Given this list of marker genes Or56b2l-ps1, Msantd7, Gm16759, Insig1, Ivd, Snx17, Psma7, Trappc14, Gls, Tet2, Hnrnpl, Dpp9, Ppid, Klc2, Nit1, Yaf2, Ogfod2, Pcif1, Bmp7, Dynll1, Gm13830, Cep63, Ddx27, Pgls, Cramp1, 1700037C18Rik, Tpgs2, Mir5615-1, Tecpr1, Gm12830, Gm5914, Men1, Dlst, Hint2, Tstd2, Mkln1os, Gm20324, Slmap, Aff4, Cfap57, Pafah1b1, Slc39a9, Iqce, Hmgb1, Srgap2, Gm15018 (NCBI Gene Id 100040987), Per1, Gm9887, Pigu, Dpm1, Cyb5rl, Gm17232, Chkb, Ociad1, Birc5, Gm17690, Ddx18, Tm9sf4, Jpt1, Bcar3, Gm4219, Dpm2, Nudt19, Pih1d2, Shpk, Tmed3, Styxl1, Polr2b, Rapgef1, 4930579G24Rik, Rbck1 (RanBP-type and C3HC4-type zinc finger containing 1), Exoc6b, Ncbp2as2, Dcp2, Psmd3, Cluap1, Hsp90aa1, Tor1aip1, Mideas, Mtg2, Ap1m1, Tbcd, Fyttd1, C030034I22Rik, Slc25a29, Dnajb14, Vcp, Polr1a, Rnf123, Pomgnt1, Plekhj1, Cspp1, Crtc2, Arih1, Bbs12 (Bardet-Biedl syndrome 12), Hdac7, Tor1a, Mesd, Dennd3, Gm28513 (NCBI Gene Id 329271), Npm1, Ift52, Tbpl1, Cd164, Mir195b, Brap, Snord49b, A430072P03Rik, Coa7, Sf3a2, Jarid2, Ptges2, Brd3, Entpd6, Tmem106b, Thap12, Zfp451, Map1lc3b, Mgat5, Agrp, Hyal3, Gpr12, Foxj3, Dnmt3b, E230015B07Rik, D030040B21Rik, Brix1, Map3k3, Slc2a1, Trim46 (tripartite motif-containing 46), Mia2, Etaa1os, Ift140, Rnu11, Ppie, Cpsf4, Trp53inp2, Mindy1, Gm34583, Pabir1, Mtmr4, Rps10, 0610031O16Rik, Ncbp2, Nup42, Mospd3, Psmc3, Cdc27, Fam98b, Dbr1, Chic2, Cd84, Dhrs11, Adck2, Mtarc2, Srp68, Tmprss11g, Nudcd3, Rplp0, Psmb8, Kank1, Arsa, Zdhhc16, Eif4g2, Tut4, Extl2, Poc1a, Atxn7l3, Zbtb7b, Mir142, Ttc33, mt-Cytb, Rpl7a, Sys1, Dido1, Srsf5, Pias3, Luc7l2, Gm22357, Scn8a, Psmb4, Trim39 (tripartite motif-containing 39), Xpo6, Bora (NCBI Gene Id 77744), Abcb6, Naa20, Zgpat, Psmb9, Ric1, Fmc1, Vamp2, Dhrs1, B230354K17Rik (RIKEN cDNA B230354K17 gene), Mir6935, Add1, Usp40, Gm11695, Naa12, Gm4285, Blcap (bladder cancer associated protein), 8430423G03Rik (RIKEN cDNA 8430423G03 gene), Sri, Hdac4, Bcap29, 1700123M08Rik, Ankrd40, Phtf1os, Zbtb37, Ica1l, Slc39a10, Nhlrc3 (NCBI Gene Id 212114), Uck1, Sbf1, Gm9694, 4930580E04Rik, Fam133b, Mir7075, Gbp3, Gm15564, Itgb1, Rhot2, Tmed7, AW554918 (NCBI Gene Id 225289), Faf1, Cacfd1, Gm14966, Mettl8, Atp6v0b, Cdin1, Timm17a, Rnf146, Cdk6, Chmp3, Cgrrf1, Uqcrc2, Gm12279, Gm26787, Gatad1, Anapc13, Stam, Npepl1, Plgrkt, Abhd4, Alg3, Rgs22, Ndufab1, Tigd5, Cyb5r4, Maml1, Erbin, Slc4a8, Kpna7, 9130401M01Rik, Alg9, Gm20716, Mfap3, Gm15410, Cct6a, Entpd7, Cdkl2, Eif2b4, Mtdh (metadherin), Mef2a (myocyte enhancer factor 2A), Rpn2, Dera, Gm27011, 0610039K10Rik, Cish, Mon1a, Rpl9, Flvcr1, Sgms1, Atpsckmt, Troap, Atp8b2, Catsper2, Pdss1, Sephs2, Zc3h4, Gt(ROSA)26Sor, 1810009A15Rik, Unc50, Zfp689, Sppl3, Abhd14a, Dennd6b, Cox7c, Utp14b, Invs, Lamtor3, Ncstn, Slc9a8, Setd1a, Ubtd2, Trip4, Wfdc3, Btf3, Oser1, 1110002L01Rik, Yrdc, Mir345 (NCBI Gene Id 723946), Rnft1, Zfp652os, Kctd9, Golga5, Nfe2l1, Gm24016, Mrpl48, Msl2, Sephs1 (selenophosphate synthetase 1), 4932435O22Rik, Arf4os, Foxm1, Gm9828, Tbc1d14, Tnip2, Pphln1, Epn1, Crk, Ptk2, Ubr1, Zbtb41, 4930558G05Rik, Vps54 (NCBI Gene Id 245944), Acp2, Lap3, 5430405H02Rik (RIKEN cDNA 5430405H02 gene), Zfp24, Ubl5, Elmod3, Ulk2, Dhx35, Elp5, Dusp10, Parp9, Pura, Tmem131, Suz12, Fbxl12os, Agk, Nudt3, Gm25222 (predicted gene, 25222), Cetn4, Mia3, Prkacb, Prkar1b, Gabpb1, 1810019N24Rik, 2310058D17Rik, Selenoh, Zkscan6, Tmem63b, Gpx4, Oxsm, Glra1, Slc15a4, Spout1, Spart, Uspl1, Supv3l1, Hsph1, Sun1, Usp5, Snord110, Oaf, Gm29642, Snord45c (NCBI Gene Id 100217425), Tlk1, Nrde2, Gtpbp10, Mdh1b, Adam17, Ece2, Rmrp, Pkn2, 4930583K01Rik, Apaf1, Ctc1, Nifk, Mrpl17, Mrm1, Gm13267, Septin11, Nelfa, AI480526, Fibp, Sfswap, Med23, Rbbp6, Trim44, Pcid2, Vhl, Mgme1, Ywhaq, Gm15938, 4930507D05Rik, Ccdc47, Phykpl, 9230114K14Rik, Gtf2e1, Tnrc6b, Rbbp4, Rad18, Kdm2a (lysine (K)-specific demethylase 2A), Cep44, Eif2a, Mir155hg, Acad12, Ube2d-ps, 4930511O05Rik, Rc3h2, Pnpla2, Atf7ip, Tob1, Stk39 (NCBI Gene Id 99416), Mir7036b, Stt3a (STT3, subunit of the oligosaccharyltransferase complex, homolog A (S. cerevisiae)), Ubap2l, Spopl, Ankib1 (ankyrin repeat and IBR domain containing 1), Ahi1, Ucp2, Espl1, Bap1, Wbp2, Tuba1c, Atp5pf, Smarcc1, Arfrp1, Mm2pr, Jtb, Iqcg, Dcun1d1, Ampd2, Ttpal, Gm11527, C130046K22Rik, Eif4g1, Slc26a6 (NCBI Gene Id 171429), Ccdc107, Exosc1, Elf2, Hirip3, Ints7, Pfdn5, Gm22711, Cdca2, Kiz, Hjurp, Mars1, Nlrp6, Ttc4, Oxa1l, Zwilch, Tmem147, Pwwp2a, Zfc3h1, Rfx1, Pex26, Grk5, Acaa1a, Gm7285, Abi2, Tgfbrap1, Rnf168, Gm11466, Eloc, Brd2, Sh3bp5l, Insig2, Rnf115, Dnaja1, Triap1, Mrps7, St13, Parp1, Hyal5, Ngdn (neuroguidin, EIF4E binding protein), 9430038I01Rik, Dctn2, Mgat4b, 5031425E22Rik, Zmpste24, Etfdh, Psme3, Ahsa2, Rpgrip1l (NCBI Gene Id 73313), Evi5, Alyref (Aly/REF export factor), Nvl, Commd3, Gm13483, Stx16, Rab29, Med27, Cdca7l, Rps27a, Pole4, Zfp592, 2310016D23Rik, Gm14448, Rhno1, Rpl35a, Mrpl32, Ruvbl1, Efcab2, Dnaaf9, Pofut1, Tmed2, Macroh2a1, Irf1, Sphk2, Srsf4, Pex5, Mir431, Cnot2, Fbxo21, Tmem131l, Trrap (NCBI Gene Id 640386), E030042O20Rik, Pnrc2, Snhg15, Xrcc5, Phf7, Kat7, Etfa, Dennd6a, Sharpin (SHANK-associated RH domain interacting protein), Mir467f, Ndufs7, Irf3 (interferon regulatory factor 3), Cnot4, Pds5a, Lamtor2, Cnbd2, Runx1, Crls1, Mta2, Galnt3, 1700016D08Rik, Rpl18, 2900093K20Rik, Spcs1, Metap2, Bscl2, Vrk2, Slc35c1, 1700022N22Rik, Plekha4, Usp19, Fto, Xpo4, Tma16, Tex264, Rabggtb, Tfb1m, Rbm39, Snord43, Ybey, Ndufaf8, Atrn, 1700065D16Rik, 9930004E17Rik, Akr1b1, Strn4, Nudcd2, Gm22879 (NCBI Gene Id 115489587), Htr5a, Azin1, Rcor1, Otub1, Zmynd12, Wdr26, Zfp866, Ino80e, Afg3l1, Snora73b (small nucleolar RNA, H/ACA box 73b), Gm7467, Hdac10, Pex13, Proser1, Prelid3b, Stamos, Ylpm1, Gm19265, Phf3, Or8b47, Adar, Ints5, Rpl31, Snora16a, Zfp764l1, Cox20, Hspd1, Ccdc34, Pogz, S100pbp, Mogs, Mrps2, Akr1a1, Sfi1 (Sfi1 homolog, spindle assembly associated (yeast)), L3mbtl2, Cnih4, Zmynd8, E330011M16Rik, Ubb, Tmem134, Slx1b, Zbtb8os, Man1a2, Coasy, mt-Tl1, Clspn, Naa60, Gm15728, Gm14963, Gm8000, Mir7672, Mir7654, Ranbp1, Ranbp2, Gm8357, Tlk2, Mir686, Bzw1, Snrk, Kdm4b, 1110004F10Rik, Cdc37l1, Spata33, Mrpl37, Tcf12, Pdf, Ppp1r14d, Pcbp3, Zfas1, Cdk9, 1700030C12Rik, Trim27, Lrsam1, Mapk14, Nudt16, Mir1893, Or5b106, Elac2 (elaC ribonuclease Z 2), 2300009A05Rik, Cbfa2t2, Rbsn, Yy1, Rps14, Cd274, Frg2f1, Ube2f, Tln1 (talin 1), Mfn1 (mitofusin 1), Rnf157, Mrtfa, Zfp639 (zinc finger protein 639), Rrp8, Snord49a, Cbx4 (NCBI Gene Id 12418), Atxn2l, Wapl, Paxip1, Snora26, Klf7, Arl8a, Ddrgk1, Prepl, Capzb, 1110020A21Rik, Dsn1, 4933440N22Rik (NCBI Gene Id 74471), Sptlc3, Fasn, Gm23201, Pabpc1, Atpaf2, Slc16a5, Tceanc2, Dyrk1a, Rpn1, Kin, Rbm5, P2rx3, Ube2d3, Gm23205, Aar2, Snord35b, Tfdp1, Ralgapb, Arhgap26, Setd1b, Tmem243, Tmem59, Erap1, Ccdc73, Slc35d1, Gm36527, Slc9a1, Svil, A930007I19Rik, A330035P11Rik, Nup54, Gm26224, Cenpk, Iqck, Gfi1, 3110083C13Rik, Abhd16a, Speer4cos, Plcl2, Aebp2, Elp1, Rsl24d1, Mrpl49, Lias (lipoic acid synthetase), 2210408I21Rik, Abl2, Nbeal1, Kat2a, Nckap5l, Ankrd44, Rbm6, Crem, Letm1, Spata31e2, Cluh, Rbpj, Myl4, Nsmaf, Zfp12, Zfp568, Cul4a, Ppig, Rpl12, Rb1cc1, Dmac2l, Egr1, Eci2, Chmp6, Or4c106, Noa1, Ptp4a1, Gm16208, Agpat3, Zfp646, 2810029C07Rik, Ttc39d, Swi5, Cdc73, Pnrc1, Exoc3, Slc20a1, Mroh8, Tcerg1, Dazap2, Ubxn1, Mrps18a, Drc3, Ppp5c, Tasor, Mre11a, Paip1, 2310061I04Rik, Shmt1, Pdp1, Snap23, Tpm3, Creld2, Phb2, Arid1a, Topbp1, Stag2, Pip4p2, Cox6c, 1700055D18Rik, Mir207, Gm5540, Usp21, Tmbim6, Ppp2r3d, Usp46, Sf3a3, Psmd11, Hdgf, Sppl2b, Zwint, Fbf1, Aldh7a1, Ptcd1, Pik3ip1, Asns, Eif1a, Atp13a3, Supt7l, Myo1c, Mrpl12, Amigo3, Tatdn2, Pus10, S1pr1, Trak2, Snord14a, 4930535L15Rik, Trpm8, Dis3l, Ap3s2, Hspb9, Lmnb2, Dram1, Orc6, Pdia3, Bag5, Trim11, Smim14, Map3k10, Hnrnph1, Vps35, Dcun1d4, Nusap1, Mtbp, N4bp2, Mrpl52, Car7, Msantd5l, Fbxo6, Supt4a, Tfb2m, Rhot1, H2aj, Gm16001, Slc35c2, Ddx39b, Ppp1r18, Pfkfb4, Eif4a1, Degs1, Astn1, Wdr77, Pimreg, Cab39l, Blzf1, Rnf14 (ring finger protein 14), Fbxo33, Rsbn1l, Hmmr, Rassf1 (NCBI Gene Id 56289), Gm12667, Eif4e2, Vps4b, Ccnk, Bud31, 5430434I15Rik, Snhg6 (small nucleolar RNA host gene 6), Smim10l1, Ccnj, Mrtfb, Oard1, Znrf3, Mbd2, Nfe2l2, Wipf1, Pramel7, Pgap2, Als2, Gm24067, Hoxc6, Glo1, Slc7a1, Arfgap2, Omg, Mocs3, 1600020E01Rik, Edf1, Zfp810, Uvssa, Dtx3l, Zmynd19, Pip4p1, 1110065P20Rik, 1700003G18Rik, Kmt2e, Stat5b, Tent4a, Rnf103, Rsph3b, Ctns, Cbll1, Snord2, Zfx, Ccne2 (cyclin E2), Tiparp, Stradb, Hsp90ab1, Hspe1, Gm16794, Cdnf, Ints15 (integrator complex subunit 15), Coa8, 5930411N13Rik, Qrich2, Zranb1, Spdye4b, Ankrd42, Exoc2, Adam9, Casd1, C430014B12Rik, Tonsl, Eef1a1, Cdk2ap2, Rpl26, Rps20, Ppwd1, Ppp1r11, Tagln2, Zfp950, Prpf19, Eif4a2, B4galt3, Minpp1, Gnptg, Rgl1, Evi2b, Rpl32, Naa15, Dnlz, Rnasel, Mpzl1, Abitram, Soat2, Pttg1ip, Rpl6, Fkbp4, Ndrg3, 5430400D12Rik, Ldha, Ccna2, Lrch4 (leucine-rich repeats and calponin homology (CH) domain containing 4), Ufl1, Stk25, Tubgcp4, Zfp777, Dusp28, Bola2, Vamp4, Pcbd2, Slc16a1, Gm13778, Dleu2, Ifnar2, Znrf2, BC049715, 2610206C17Rik, Pradc1, 4931406C07Rik, 2810013P06Rik, Terf2, Lrrc24, mt-Nd1, Arl6ip6, Antxr2, Gm4825, 2810405F17Rik, Toe1, Qrich1, Ptp4a2, Cep350, Wdr73, Akirin2, Cfap68, Gm22107, Gm13610, Rab7, Cdca5, Atp5mk, Snx5, Asb1, Ep300 (E1A binding protein p300), Ndufs8, Ilk, Snhg7os, Defb25, Acad11, Tsacc, Gabpb2, Galnt1, Dus2, Slc25a1 (NCBI Gene Id 76777), Gm11802, Tax1bp3, Pmpcb, Gm25878, Gm40190, Dap3 (NCBI Gene Id 80429), Rsrc1, Cibar1, Senp1, Trappc8, Zfp276, Zdhhc24, Zfp523, Gsap, Tmco1, Utp3, Dram2, Commd6, Usp8, Mir3091, Znhit3, Slc25a19, 4933405D12Rik (RIKEN cDNA 4933405D12 gene), C330013E15Rik, Snord68, Camkmt (NCBI Gene Id 73582), Set, Ptpa, Amfr, Pithd1, Dync2h1, Ddx6, Ei24, Fastk (Fas-activated serine/threonine kinase), Bcl7c, Ddx31, Cdkn2c, Bag1, Zfp668, Sp8, Sap30l, Ikbip, Txndc5, Lrrc41, Psmb7, Nt5m, Epc1, Dclre1a, Rubcn, Dvl3 (dishevelled segment polarity protein 3), Snora7a, Xpnpep3, Rock1, Nufip2, Akap9, Nt5c3b, Zfyve1, Smurf1, Gstp1, Trpc4ap, Mvb12b, Cd27, Stk38, Trbj2-6, 2010109A12Rik, 0610009E02Rik (NCBI Gene Id 100125929), 1600023N17Rik, Nfyb, Tex14, Ipo13, 2310040G07Rik, Retsat, Pdk1, Tomm7, Rragc, Nfkbid, Vps9d1, Guf1, Hspa8, Cir1, Zfp386, Zfp217, Alg12, Ptbp3, 8430432A02Rik, E130102H24Rik, Recql5, Pdhb, Armc8, BC018473, Mmadhc, Elf1, Tmco5, Ncl, Ubxn8, N4bp2l1 (NCBI Gene Id 70229), Dgkeos, 4930578M01Rik, Far1, Zcchc9, Snora78, Trp53rkb, Arl2bp, Syncrip, C6, Pcna, St7l (suppression of tumorigenicity 7-like), Spata13, Prdx6, 5830437K03Rik, Api5, Abhd14b, Eif4enif1, Tnip1, Eif6, Rpl3, Ebna1bp2, 1810055G02Rik, Ankle2, Snora3, Rcc1, Glrx2, Lsm14a, Zswim1, Mbd5, B230369F24Rik, Rfc3, Gtf3a, 4732440D04Rik, Ptges3l, Pkmyt1, C8g, Rexo4, Qtrt2, Vps37a, Uhmk1, Matr3, Gm17344, Cpeb3, Gpd2, Gtf2b, Ipo4, Mir6236, Rrp7a, Ccl5, Lbhd1, Kbtbd2, Coa5, Sec62, Aco1, Cul3, Gm16279, 2310001K24Rik, Dhps, Atr, Rnf114, Usf1, Nat9, Zfp593, Ppm1a, Gmppb, Gm22489, Aurka, Ebag9, Safb2, Dnajb4 (NCBI Gene Id 76019), Gng10, Wdr12, Ubqln4, Nfkb2, 2900009J06Rik, Pcgf1, Usp1, Tsc22d2, Gm9958, Gm10518, Pprc1, Dph6, Rufy3, Appbp2os, Gm49405, 6330418K02Rik, Vamp1, Sub1, Krcc1, Mir17hg, Bpgm, Smpd4, Usp14, Rnf4, Chmp4b, Rpl27, Uqcrh, Apobec1, Jag1, Stam2, Gm15420, Tmem147os, Gm26205, Vgll4, Gne, Gorasp2, Slc4a1ap, Slc25a39, Senp6, Bcas3, Uba6, Scarb2, Snora24 (small nucleolar RNA, H/ACA box 24), Vps13b, Creb3, Wdr70, Arhgef4, Rps27l, Pomt1, 1700034K08Rik, Wac, Rbm4, Trim33, Psme1, Sox21os1, Sp6, Brd4, H1f0 (H1.0 linker histone), Scrt1, Slc46a3, Caprin1, A230083N12Rik, Brd10, Nup58, Aamdc, Polr3c, Mob1a, Pcca, Nop56, Chac1, Cdc25a, Tmem168, Ywhaz, Nfs1, Abl1, Scly, Gm15952, Tmem43, Frmd8os, Acox3, Gm22973 (predicted gene, 22973), Gtdc1, Snrpa, Triobp, Snora73a, Ptcd2, Rfc5, Emg1, Eif1, Phtf1, Zc3h18, Aven, Ndufb2, Fam193a, Rbak, Capza2, Dclk2, Cand1, Ybx1, Bag6, Lmo7, Mark2, Gm42759, Gm29257, Usb1, Marchf6, Maf1, Gm21992, Gm2479, Nr2f1, Nsfl1c, Snora17, Ppa2, Wbp11, Rtl9, Ibtk, Ccl25, Vipas39, Rptor, Mutyh, Fitm2, Pdzd2, Ythdf2, 0610009L18Rik, Ndufv1, Prpf39, Psd4, Ice2, Gm9889, Lpcat1, Wdr20, Ttc14, Sugct, Dhx30, Rab11fip2, Map2k2, Dnttip1, Anapc11 (anaphase promoting complex subunit 11), Arid4a, Kpna1, Zfp691, Mettl6, Drg2, Taok1, N4bp2os, Gm27003, Actg1, Zscan29, Rcbtb2, Cga, Rpf1, Orai1, Mir762, Zmym5, Herc1, Zdhhc7, Znfx1, Ss18l1, Rps29, Foxp1, Dynlrb1, Bbof1, Ube2j2, Cul5, Ndufa12, Cit, Iqch, Gm10138, Cntd1, Stard7, Prkar1a, Zfp672, Gba2, Fancm, Fbxo9, Gm11520, Mir155, Rgp1, Cutc, 1700052K11Rik, Tmem115, Zmynd11, Brwd1, Rabl3, Capn15, Ramac (NCBI Gene Id 73684), Cnnm3, Cacng2, Peli1, Cwc22, Thap2, Sp1, Rpl5, Rps6ka1, Ahsa1, Zbtb5 (zinc finger and BTB domain containing 5), E2f1, Trbj2-7, Atp2a2, Raly, Lpin2, Rpp14, Sf1 (splicing factor 1), Myo9a, Gm22589, Smarcd1, Trappc4, Ric8a, Banf1, Cd24a, Rad54l2, Actb (NCBI Gene Id 11476), Arfgap1, Ppp4r1l-ps, Mrpl13, Cntn1, Pfkfb2, Prmt5, Prpf4, Ankrd17, Gm57488, Brd7, Efr3a, Zfp709, Eif5, Erp44, Inhca, Tesk1, Rnaseh2c, Gosr2, A130014A01Rik, Acp6, Ythdf1, Acad10 (acyl-Coenzyme A dehydrogenase family, member 10), Aatf, 3110031N09Rik, Gpr19, Snora9, Txnrd2, Dnajc8, Capza1, 3110056K07Rik, Tmem268, Zfp62 (zinc finger protein 62), Krit1, Ppp2r5c, Cnst, Zfand5, Gphn, Gm11592, Srsf7, Dnajb6, Zfp597, Kmt5b, Ubtf, Fbxo24, Hnrnpa1, Birc6, Gm16124, A430018G15Rik, Eif3c, Fam227b, 1110025M09Rik (RIKEN cDNA 1110025M09 gene), Tef, Clec16a, Pank2, Rpl36al, Kcmf1, 0610030E20Rik, Gm13562, Bcl2l12, Gm10459, Sumo2, Anapc5, Xbp1, Cstb, Zfyve28, Snhg3, Mir8113, Sdhaf2, Samd13, Crat, Med22, Cct3, Dusp16, 4931422A03Rik, Atad5, Recql4, Pan3, Abcc10, Cage1, Tmprss11f, Pomp, Ciao1, Gnl3l, Lrrfip2, Gucd1, Ammecr1l, Axin1, Slain1, Ddx21, Gm40332, Pdss2, Stap1, Higd1a, Yipf4, Tsr3, Rps19, Gga3, Thoc2, Myg1, Mdm4, Gm42918, Ppm1g, 4930592C13Rik, Mir7b, Nme7, Ckap5, Gm5447, Axin2, Gm13990, Ube2k, Irgm1, Psph, Furin, Zzz3, Ttc21b, Tmem94, Nr2c2, Hexim2, Zfp263, B930094E09Rik, Azi2, Mir7058 (NCBI Gene Id 102466797), Cebpg, Bphl, 4930502E09Rik, Ptger4, Tfrc, Ccnd3, Acsl1, Asnsd1, Crebzf, Prdm15, Zfp219, Gas5, Fip1l1, Rab43, Tmem170b, Gm26513, Hspa5, Zkscan17, Ssbp2, Dusp5, Trmt1l, Vegfa, Ywhab, Ostf1, St7, Ythdc1, Arl15, Nmrk1, Zfp644, Fbxw4, A730017L22Rik, Clhc1, Cstf3, Nfu1, Cdk12, Cept1, Tbca, 2010001A14Rik, Dmap1, Tepsin, Gm4419, Ints14, Ptpmt1, Stk24, Atp2c1, Ddx1, Rpl21, 4933439C10Rik, Ppp1r2 (NCBI Gene Id 74865), Ankdd1b (NCBI Gene Id 271144), Ubl3, Gm17399, Arfgef1, Dcaf8, Prr13, Ube3a, Zc3h7a, Arhgap39, Slc7a11, Pcmt1, Ubc, Mir3569, Homez, Ublcp1, Snhg12, Zfp746, Cmtr1, Cbx5, Aip, Usf2, Mrpl58, Zfp143, Wrap53, Rps2, Gm10069 (NCBI Gene Id 791299), Krt6b, Sacm1l, Rprd2, Gm10222, Bcl2l13, Kpna2, Hmgn2, Fbxw11, Fry, Ak5, Tbce, Ppp4r1, Dolk, Rad1, Zfpl1, Nxf1, Snx13, Naa80, Zcwpw2, Tpt1, Zfp410, Cdca3, Mir5122, Ube2e2, Tanc1, Rhbdd3, Dnajc17, Gm5129, Fam222a, Stoml2, Trmt2a, Ergic2, Ly75, Scaf8, Crot, Smarcal1 (NCBI Gene Id 98463), Csnk1g2, Katnal1, Rnf44, Ahcyl1, Smchd1, Cggbp1, Haus8, Cyb5a, here is a description of the gene set: Genes containing one or more binding sites for (Ccl5) in their promoter regions (TSS -1000,+100 bp) as identified by GTRD version 20.06 ChIP-seq harmonization. from publication Yevshin I, Sharipov R, Kolmykov S, Kondrakhin Y, Kolpakov F (PMID 30445619) Mouse Gene Set: CCL5_TARGET_GENES species: Mus musculus